Given this list of marker genes PDXP, SGPP2, MTMR11, CTDP1, THTPA, EPHX2, DUSP4, CDC14B (NCBI Gene Id 8555), PPM1A, PPEF2, PTPN14, PTPN7, PTPRR, PLPPR4, PTPRT, PTPRU, SMG6, CTDSP1, PTPN9, SBF1, CHP2, PTPRK, FIG4, SYNJ2, DUSP7, STK11, SMG5, MTM1, DUSP18, PPM1E, PTPRS, INPP5J, INPPL1, CHRM5, GPLD1, PTPN12, DUSP28, PDP1, PTPN18, DUSP1, DRD2, SSH1, SSH2, PTPRZ1, MTMR1, PTPRB, PTPN11, PPM1D, MTMR10, DAPP1, PTPN4, INPP5K, ADORA1, PTPN2, CTDSP2, PTPN6, PPM1M, TIMM50, PPM1B, SRC, CTTNBP2NL, PLPP2, PPEF1 (protein phosphatase with EF-hand domain 1), DUSP8, PTPRE, DUSP11 (dual specificity phosphatase 11), DUSP13A, MTMR7, DUSP2, SYNJ1, SDHAF2, CHP1, ALPI, PPP2CA, PPP1R17, PPP5C (protein phosphatase 5 catalytic subunit), FBXW11, PPP3CC, BTRC, PPP2CB, PPP1CA, PPP1CB, PLPPR5, DUSP9, IGBP1C, IGBP1, MTMR6, PLPPR1, ACP3, PTPRJ, PTPRF, PPP3CB, DUSP6 (dual specificity phosphatase 6), MTMR3, PIP4P2, DUSP13B, INPP5D, CDK5RAP3, INPP5B, DUSP16, PTEN, PPP3CA, PPP6C, URI1, DUSP29, INPP5F, DUSP15, TNS2, PTPN13, DUSP3, SACM1L, OCRL, INPP5A, MTMR9, MTMR4, SMG7, PPP2R3C, PTPRH, SGPP1, DUSP23, MTMR2, PLPP6, PIP4P1, DUSP21, PLPP1, PPP2R3B, INPP5E, PLPPR3, DUSP12, PPM1G, CTDNEP1, DUSP5, PTPRN2, IQGAP1, PLPP5, MTMR12, PTPN21, PPP2R2A (protein phosphatase 2 regulatory subunit Balpha), PLPP4, PTPN1, DUSP26, PPP2R3A (protein phosphatase 2 regulatory subunit B''alpha), PPP1R12A, MTMR8, TPTE, PTPRC, BMP2, PLPP3, NT5C, DUSP10, ACP4, PTPN5, PLPPR2, EPM2A, PTPN22, PPP1CC, here is a description of the gene set: species: Homo sapiens Human Gene Set: GOBP_DEPHOSPHORYLATION The process of removing one or more phosphoric (ester or anhydride) residues from a molecule.